The following is a description of a gene set: RUNX3 regulates p14-ARF Mouse Gene Set: REACTOME_RUNX3_REGULATES_P14_ARF studied in species Mus musculus, and this is the list of marker genes: Hdac4, Ccnd1, Runx3, Ep300, Cbfb, Tgfb1